The following is a description of a gene set: The directed movement of substances mediated by an endosome, a membrane-bounded organelle that carries materials enclosed in the lumen or located in the endosomal membrane. studied in species Mus musculus Mouse Gene Set: GOBP_ENDOSOMAL_TRANSPORT, and this is the list of marker genes: Emp2, Snx16, Eps15, Atp6ap1, Vti1a (vesicle transport through interaction with t-SNAREs 1A), Mtmr4, Chmp2b, Pheta2, Tbc1d10b, Pik3c3, Trim27, Map2k1, Spag9, Prepl, Magel2, Ehd3, Rab7b, Vps25 (vacuolar protein sorting 25), Arfrp1, Baiap3, Myo1d, Fhip1b, Mcoln1, Vti1b, Rab8b, Rab12, Washc5 (NCBI Gene Id 97946), Bet1l, Reps2, Ankrd27, Arfip1, Rab29, Tbc1d23, Snx30, Fcgr2b, Wdr81, Eipr1, Atg14, Cltc (clathrin heavy chain), Rufy4, Nsg2, Rhobtb3, Vps54, Bcl2l1, Vps50, Erc1, Snx1, Rab6a, Rab13, Ndrg4, Itsn2, Snx17, Nsg1, Lrp2, Snx4, Caly (calcyon neuron-specific vesicular protein), Reps1, Vcp, Hook1, Ccdc93, Mtmr2, Vps4b, Stx5a, Commd1, Vps52, Rab11fip3, Dennd1b, Chmp3, Chmp5, Als2, Stx12, Wipf3, Pikfyve, Tbc1d14, Lyst, Chmp1a, Stam, Rab8a, Bloc1s2, Tom1, Stx8, Vps51, Lamtor1, Cdc42, Dnm1l, Akap5, Mvb12a, Vps26c, Micall2, Tbc1d17, Sorl1, Sgsm2, Bltp1 (NCBI Gene Id 545514), Washc4, Arhgap44, Arf6, Snx5, Rab21, Ap5m1, Arhgap1, Vps28, Tbc1d10c, Plekhj1, Rnf126, Ezr, Msn, Vta1, Trarg1, Lrrk2, Atp9a, Vps53, Vps26a, Ap5b1, Wdr91, Rab4b, Dync1li1, Gga3, Plekha3, Actn2, Ankrd50, Mapk3, Evi5, Map2k2, Rilp, Washc3, Ehd4, Itsn1, Chmp4c, Chmp1b, Rab7, Rgp1, Arl8b, Coro1c, Snx8, Ighm, Grip2, Agap2, Zdhhc2, Chmp6, Tmem50b, Cracr2a, Golt1a, Scarb2, Gosr1, Hgs, Tmem87b, Micall1, Vamp4, Bloc1s1, Snx6, Ehd1, Slc66a2, Rab6b, Rab9b, Vamp3, Gbf1, Rbsn, Dennd5a, Vps4a, Snx31 (sorting nexin 31), Ccdc22, Rab11b, Arl1, Gripap1, Golt1b, Src, Vps35l, Rdx, Leprotl1, Rufy1, Ube2o, Clec16a, Dennd1c, Ap3d1, Dpy30 (NCBI Gene Id 98088), Sort1 (NCBI Gene Id 99747), Pik3r4 (NCBI Gene Id 97556), Snx3, Becn1, Epg5, Anxa8, Snx33, Vps29, Entr1, Ubxn6 (NCBI Gene Id 76275), Chmp4b, Arhgap8, Cln5, Acap2, Pheta1, Rab11fip4, Nf2, Rab11a, Stx7, Myo5b, Vps39, Trappc10, Lrba, Tmem50a, Leprot, Snx9, Hook2, Eps15l1, Coro1a, Lrrc7, Vps13b, Ptpn23, Usp7, Rab14, Laptm4b, Dennd2a, Alms1, Snx32, Vps26b, Rab9, Ykt6, Cmtm6, Vps35, Aktip, Kif16b, Snap25, Diaph3, Dctn1, Zfyve9, Bltp3b, Chmp7, Vps16, Ankfy1, Heatr5b, Mapk1, Zfyve16, Tmem87a, Snx18, Washc2, Inpp5f, Dab2, Lmtk2, Snx2, Pla2g4e, Gcc2, Vps36, Tbc1d5, Dennd10, Picalm, Ap1s1, Snf8, Was, Rab17, Grip1, Rab10, Scrib, Hook3, Sh3glb1, Gga1, Ehd2 (NCBI Gene Id 259300), Heatr5a, Ap5s1, Flna, Als2cl, Ap5z1 (adaptor-related protein complex 5, zeta 1 subunit), Dennd1a, Snx7, Ric1, Abca1, Chmp2a, Ap1s2, Rcsd1, Bves, Snx12, Arl4c, Vps11, Pla2g3, Tbc1d10a, Htt, Snx27, Stx16, Rab35, Dnajc13, Stx6, Btbd8, Chmp1b2, Tmcc1, Washc1, Rab5a